The following is a description of a gene set: studied in species Mus musculus Reactome Pathway: Striated Muscle Contraction This event has been computationally inferred from an event that has been demonstrated in another species.<p>The inference is based on the homology mapping from PANTHER. Briefly, reactions for which all involved PhysicalEntities (in input, output and catalyst) have a mapped orthologue/paralogue (for complexes at least 75% of components must have a mapping) are inferred to the other species. electronically inferred by orthology from the curated human pathway part of: Muscle contraction, and this is the list of marker genes: Vim, Mybpc2, Tmod3, Tmod1, Tmod4, Tpm3, Tnnt1 (troponin T1, skeletal, slow), Myh3, Tmod2, Tnni2, Myl1, Tnnt3, Tpm2, Myl2, Tnnc2, Myl3, Acta1, Tnnt2, Actn3, Des, Tnni3, Tnnc1, Tcap, Actc1